Given this list of marker genes SPPL2B, RHBDD1, NCSTN, MBTPS2, SPPL2A, SPPL2C, HM13, PSENEN, MMP7, TGFB1, MBTPS1, APH1A, ADAM9, APH1B, here is a description of the gene set: Human Gene Set: GOBP_MEMBRANE_PROTEIN_INTRACELLULAR_DOMAIN_PROTEOLYSIS species: Homo sapiens The proteolytic cleavage of a transmembrane protein leading to the release of an intracellular domain.